Given this list of marker genes MSTO1, PIK3CD, ERGIC1, GFM2, SLC16A2, GIPC1, MYH7, TANGO2, KNSTRN, RILPL1, GOSR2 (NCBI Gene Id 9570), SLC6A8, COL25A1, EBF3, PIEZO2, HACD1, BCL11B, CRELD1, TBCK, DPM2, NOTCH2NLC (NCBI Gene Id 101060315), CCDC174, GLE1, MYL1, LRP12, MYH2 (NCBI Gene Id 4620), VAMP1, NEB (nebulin), SLC6A9, MYL2, KCNH1, SGCB, VPS41 (NCBI Gene Id 27072), SCYL2 (SCY1 like pseudokinase 2), UBA1, GMPPB, TPM3, DMXL2, SELENON, TPM2, ACTA1, ITGA7, MAP3K20, RYR1, SLC52A3, TAFAZZIN, SLC9A7, STAC3, HOXB1, PYROXD1, LAMA2, PURA, TNPO2, TNNT1, CERT1, SPTBN4, KLHL41, PTRH2, here is a description of the gene set: Myopathic facies studied in species Homo sapiens A facial appearance characteristic of myopathic conditions. The face appears expressionless with sunken cheeks, bilateral ptosis, and inability to elevate the corners of the mouth, due to muscle weakness. Human Gene Set: HP_MYOPATHIC_FACIES